The following is a description of a gene set: studied in species Mus musculus Catalysis of the transfer of an L-fucosyl group from GDP-beta-L-fucose to an acceptor molecule to form an alpha-(1->3) linkage. Mouse Gene Set: GOMF_ALPHA_1_3_FUCOSYLTRANSFERASE_ACTIVITY, and this is the list of marker genes: Fut11, Fut9, Fut4 (fucosyltransferase 4), Fut10, Fut7